The following is a description of a gene set: TGFA-EGFR-PI3K signaling pathway. Pathway ID: N00231. Pathway type: Reference. Pathway class: nt06260 Colorectal cancer. Human Gene Set: KEGG_MEDICUS_REFERENCE_TGFA_EGFR_PI3K_SIGNALING_PATHWAY Pathway Definition from KEGG: TGFA -> EGFR -> PI3K -> PIP3 -> AKT -> MTOR studied in species Homo sapiens, and this is the list of marker genes: TGFA, PIK3CB, AKT1, PIK3CD, PIK3CA, MTOR, AKT2, EGFR, AKT3 (NCBI Gene Id 26068)